The following is a description of a gene set: Human Gene Set: MODULE_462 Eicosanoid metabolism (and related carboxylic acid biosynthesis). studied in species Homo sapiens, and this is the list of marker genes: UGDH, LTA4H, PTGIS, HSD17B4 (NCBI Gene Id 3295), ALOX5, AKR1C3, PTGS2, ALOX5AP, ALOX15, PTGDS (prostaglandin D2 synthase), HPGD, FDXR, MGST2, CYP4F3, ALOX15B